The following is a description of a gene set: Human Gene Set: GSE20500_CTRL_VS_RETINOIC_ACID_TREATED_CD4_TCELL_DN This is to determine the T cell genes regulated by retinoic acid. from publication Kang SG, Park J, Cho JY, Ulrich B, Kim CH (PMID 20664575) Genes down-regulated in CD4 T cells: control versus tretinoin. species: Homo sapiens, and this is the list of marker genes: PPP1R11, SH3BP5, OSGIN1, GPC4, LRRFIP2, SLC25A32, ELK1, RUSC2 (NCBI Gene Id 9853), SPATA31C2, MAP1B, FGF18, ZNF771, IER5, PLOD3, CENPT, ADRM1, IGFBP2, ERICH1, PSG1, OR52A1, GOLGA2, PMFBP1, SEC16A, WHRN, MFSD6, FOXO1, ACVR1B, AMMECR1, SEMA6A, COQ7, RAB3GAP1 (NCBI Gene Id 338380), MPO, FGF7, IPO7, SLC38A4, YBX3, FGB, CTSV, GRIN2B, CSNK1G1, CCNP, ATP2A2, TNFSF14, KATNBL1, HEXIM1 (NCBI Gene Id 10614), GAS1, FOLR2, RUBCN, GTF2F1, TPSD1, PABPC4, UNC5C, SPTBN5, CHST8 (carbohydrate sulfotransferase 8), TYMP, FTSJ1, F2R, MYO1B, COL7A1, TCP11, HTR7 (5-hydroxytryptamine receptor 7), SLC8A2, KCNN4, SLK, GSN, KHNYN, ZNF143, ARAP3, NPAS3, YTHDC1, AKAP8 (NCBI Gene Id 10270), BTN1A1, OSMR, PYGL, TRDMT1, KATNIP, MAGEA11 (NCBI Gene Id 4110), ACTA1, PPP1R2C, DCP1A, NFKB2, GDAP1, NRIP3, APOM, KLF3, POMP, SNRK, ACE, ICAM2, IFIH1, DNAJC12, WDR26, USP2, PPIF, GSK3B, COQ2, CBX4, TNFSF13, AK1, IL18R1, DPF1, ITGAM, PI4K2A, RC3H2, SEC23B, CLUHP3, CLK1, COL6A3, PLEK2, CD59, MX1, PAH, TBXAS1, RPL13P5, DOT1L, TMEM51, LMCD1, SYCE1L, CDV3, CLEC5A, AEN, RAB22A, ILRUN, SFT2D2, DNASE1L2, CEBPB, SPTBN1, SHROOM2, PLEKHA4, ENSG00000289047, ITPR3, MELTF (melanotransferrin), TNFRSF12A, CYP2U1, RGS17, LINC01565, YWHAH-AS1 (YWHAH antisense RNA 1), S100A6, RHOBTB3, ITM2C (integral membrane protein 2C), MAMLD1 (mastermind like domain containing 1), SLC3A2, PRODH2, CSGALNACT2, SORT1, MEIS3P1, PSMD13, TOPORS, DDX27, ZMAT3 (zinc finger matrin-type 3), TNFRSF4, BAZ1A, TUBA1A, TRIM21 (tripartite motif containing 21), ACBD3, ITGB1BP2, CLTC (NCBI Gene Id 9511), GNAI3, PPEF2, CRABP2, RTF2, TNNC2, STAT3, MYT1, MTCH1, TGFBR3, EFNA2, PFKFB3, PDE6G (phosphodiesterase 6G), H2BC21, PFDN2, SPDEF, BCAR3, TSSK1B, CYP4F2, CST7, CMC2, MYO6, CLMN, CTSF, DXO, SLC17A4, FBRS, BTG3, KRT83, SCARF1, KLF7, ZKSCAN1, GARRE1, HIPK3, SORBS3, CTSH, FAS (Fas cell surface death receptor), HAPLN1, ASCC1, RHBDL1, ERP44, RB1CC1